Given this list of marker genes Gps2, Cd22, Cd81, Nfam1, Lpxn, Cd19, Prkch, Cd300a (CD300A molecule), Stap1, Ptpn6, Gcsam, Cmtm3, Fcrl5, Plcl2, Slc39a10, Fcmr, Lyn, Foxp1 (NCBI Gene Id 73231), here is a description of the gene set: Mouse Gene Set: GOBP_REGULATION_OF_B_CELL_RECEPTOR_SIGNALING_PATHWAY Any process that modulates the frequency, rate or extent of signaling pathways initiated by the cross-linking of an antigen receptor on a B cell. studied in species Mus musculus